The following is a description of a gene set: studied in species Mus musculus Mouse Gene Set: chr17D, and this is the list of marker genes: Znrf4, Uhrf1, Gm16712, Gm5815, Cd70, Mir6978 (microRNA 6978), A230051N06Rik, Safb2, Rpl36, Plin4, Ranbp3, Fut4-ps1, Gm23769, A330072L02Rik, Zfp959, Kdm4b, Prr22, Gtf2f1, Mir6977, Shd, Tnfaip8l1, Mllt1, Rfx2, Dennd1c, Tnfsf9, Gm49848, Slc25a23, Catsperd, Gm11110, Vmn2r120, Ndufa11, Acsbg2, Tincr, Gm6149 (predicted gene 6149), Chaf1a, Trip10, Rpl7a-ps5, Arrdc5, Gm17949, Adgre1, Gpr108, Vav1, Ticam1, Gm18139, Mpnd, Zfp119b, Lrg1, Fsd1, Tnfsf14, Rpl21-ps6, Crb3, Sema6b, Clpp, C3, Ptprs, Safb, Gm49852, Nrtn, Fem1a, Dpp9, Alkbh7, Nudt12os, Hdgfl2, Acsbg3, Tubb4a, Ebi3 (Epstein-Barr virus induced gene 3), Nudt12, Zfp119a, Pspn, Mir7b, Gm25102, Khsrp, Slc25a41, Gm9284, Plin3, Gm17920, Plin5, Dus3l, Gm18417, Micos13 (mitochondrial contact site and cristae organizing system subunit 13), Yju2, Ubxn6, Vmac, Cntnap5c, Sh3gl1, Gm23203, Gm16276, Stap2 (NCBI Gene Id 240122), Pdzph1, Lonp1, Gm46575 (NCBI Gene Id 108168318), Mydgf, Acer1